The following is a description of a gene set: species: Homo sapiens Apnea Human Gene Set: HP_APNEA Lack of breathing with no movement of the respiratory muscles and no exchange of air in the lungs. This term refers to a disposition to have recurrent episodes of apnea rather than to a single event., and this is the list of marker genes: KAT6B, FGF8, SFTPB, NR4A2, TSPYL1, MT-TK, TSEN34, BICD2, GRIN1, PLPBP, PRNP, TMEM138, SNAP25, SOX9, PIGA, FGF13, CDKL5, PHOX2B, TCIRG1, CEP104, MYO1H, SEPSECS, SYT1, CAPNS1, MKS1, TMEM231, PTF1A, ARMC9, WFS1, SNX10, PRRT2, MYL1, KIF7, KIAA0586, STAT2, SUFU, MAGEL2, MT-ND1, LIAS, AMER1, HTRA2, SCN8A, SKI, PCK1, GAS1, PDE6D, MT-ND2 (mitochondrially encoded NADH:ubiquinone oxidoreductase core subunit 2), CPLANE1, CEP57, SLC1A3, PTCH1, FAM149B1, PI4KA, RARS2, CHRNE, SLC25A12, NDUFS4, ADAM22, GCSH, TOE1, TMEM237, AHI1, RBM10, B9D2, HDAC9, MT-ATP6, CEP120, FGFR1, SATB2, ARL3, MECP2, NTNG1, PCCA, SLC25A20, MINPP1, CSPP1, HDAC4, SUCLG1, DDC, INPP5E, DST, STIL, MYO9A, GNAI3, NDUFA6, GLRA1, MCCC1, COQ4, MT-ND5, TMEM218 (NCBI Gene Id 219854), NDUFS1, BUB1, PEX5, STAG2, NDUFA11, SLC6A9, AGRN, B9D1, CRYAB, AP3D1 (NCBI Gene Id 8943), ALPL, PDHA1, TSEN15, NDUFA2, NDUFAF2, RNU4-2, CLCN7, ACY1, NDUFS8, MT-TL1, BUB1B, NFIX, SCO1, RPGRIP1L, GBA1, HMGCL, GPHN, TCTN1, TTC19, DISP1, ACADSB, KIF5A, D2HGDH, GLI2, NDUFV1, PLAA, DPAGT1, PCCB, TMEM107, PSAT1, SCN4A, HACD1, ADGRG1, CDON, CACNA1A, NPHP1, OPA1, IFT74, ZNF423, NODAL, DLL1, FGFR3, KCNQ3, SYT2, CHAT, FARS2, CEP290, MT-ND3, ZC4H2, SLC2A1 (solute carrier family 2 member 1), BCHE, LIFR, SNRPN, NAA10, PLCH1, CEP41, SMC1A, SLC5A7, TBR1, ATP5F1A, MTHFR, SLC39A8, CAMK2B, NEB, SRPX2, TNFSF11, CRIPTO, TCTN2, NDUFS2, CBY1 (NCBI Gene Id 25776), PRKAG2, SLC18A3, NUP214, HSPD1, PLA2G6, NACC1, PEX13, ZIC2, ATP1A3, TMEM67, HYLS1, CC2D2A, GNB2, FOXH1, MT-ND4, TOPORS, SLC6A5 (solute carrier family 6 member 5), TRIP13, FBN1, TOGARAM1, SCN2A, SHH, BRAT1, MT-TW, TCTN3, TSEN2, ASXL1, HSPG2, CTSD, SCN5A, ABCA3, VAMP1, CPT2, NDN, TGIF1, KATNIP, PLCB4, TSEN54, GRIK2, MT-ND6, ARL13B, FBP1, TMEM216, CISD2, PSAP, CRLS1, LBX1, GABBR2, OFD1, ATP1A2, SIX3, COL13A1, KCNJ11, TECPR2, ECHS1 (NCBI Gene Id 1892), MRPL39, GLUL, RNF125, OCA2, KCNQ2, MT-TV, KIAA0753, MOGS (mannosyl-oligosaccharide glucosidase), NEK1, BUB3, ARSL, BTD, SLC25A1, PURA, PIBF1